Given this list of marker genes COQ8A, SYNE2, SHROOM1, GALC, KMT5B, CYP4F2, SRR, HTATSF1, DCN (decorin), CFHR1, ZNF419, MUSTN1, CLCC1, ALDH6A1, CORIN, EVA1A, SULT1B1 (sulfotransferase family 1B member 1), GLYAT, PLXNC1, DDX60, AKR1D1, CELF2, CLCN2, HAAO, UGT2A3, CRYAB, BLMH, MFN1 (NCBI Gene Id 55669), TEX21P, UGT3A2, CYP4V2, TCF21, PRLR, ENPEP, CTNNBL1, NTN1, IGF1, TTYH1, MCM10, CXCL12, SERPINE2 (NCBI Gene Id 5270), UPP2, IMMP2L, KIF1B, GAS1, TBC1D8, ABHD3, ACSS2, ACAD8, NGFR, MSI2, S100A1, TEX12, ZNF35, PRKAG2, CHCHD7, GPM6A, AASS, SLC26A3, CLEC4G, TRAF3IP2 (NCBI Gene Id 25997), EDNRA, CD320, CHPT1, PNKD, KCNQ5, PMPCB, GABRE, HIBADH, CALCRL, PARK7, OLIG1, SLC47A1, HACL1, CLEC4F, UGT2B4, CNMD, HLA-B (major histocompatibility complex, class I, B), DNASE1L3, DPYS, ACAD9, DENND2B, N4BP2L1, DCUN1D1, IL1RAP (NCBI Gene Id 3556), CYP2D6, GOT1, L2HGDH, BAG4, ACAT2, CCNF, HPGD, NAT2, SLC2A5, CYP2J2, DCT, CCR5 (NCBI Gene Id 727797), SELENOW, CLPX, TSPYL4, GFER, MAGIX, RBBP9 (RB binding protein 9, serine hydrolase), CYP8B1, MBL2, TERF2IP, SPPL2B, NDRG2, PJA1, DPYD, AGXT, STARD5, AGMAT, RGS5, FCGR2B, PDK1 (pyruvate dehydrogenase kinase 1), CD163, ITGA9, CLOCK, CES1, OTC, SLC16A2, PCCA, IDH1, CYP2G1P, SUSD4, IDO2, SIRT3, ABI3BP, SOCS7, BAAT, ACADSB, SLC22A25, ASL, PAICS, CA3, CYP2C8, PTPRO, STAB2, DCXR, TSHB, RMDN3 (regulator of microtubule dynamics 3), DSCAML1, ATAD3A, GABRA1, PTPRD, RNASEL, AADAT, FZD9, GDF10, ABCB10, NDUFB9, NR2F2, TGFB3, ABHD15, MKRN1, ALDH1A1, PCOLCE2, CD3E, PECR, EHD3 (EH domain containing 3), SLC25A15, HEMK1, SARDH, EPDR1, GPX1 (glutathione peroxidase 1), MACROD1, BHMT2, ARHGAP6, MFSD4B, ZNF865 (NCBI Gene Id 100507290), NDN, CES3, SLC17A2, KIFC2, ATG5, MDH1, CSRP3 (cysteine and glycine rich protein 3), TPRKB, HOXC9, PPP2R5C, ALDH9A1, ADAMDEC1, GLO1, ADHFE1, GDF2, GALM, LEAP2, CBS, CNGA2, CLEC3B, SLC22A7, CD1D, AHCY, HMGCS2, CKMT2, NR1H4, GSTO1, RNASEK, DENND1A, AANAT, BAD, RDH16, CD40LG, ID4, PLEKHB1, KCNK5 (NCBI Gene Id 8645), ACYP1, CPHXL, MAST3, ABAT, AMY2B, MBL1P, ACSL1, SLC10A1, SOD3, ATP11A, NAT8, DMGDH, TCF25, DDC, ETHE1, RNF19B, HAGH, SLC25A51, CYP2F1, ADH4, ALDH8A1, MTCH2, GHR, CWC15, GCDH, PDE9A, TIMM9, RAB3A, PTH1R, SUCLG2, EPHX2, GCH1, GAS2, ACAT1, GDPD3, SLC6A12, SUOX, MASP1, ADTRP, ZEB2, EFEMP1, INMT, IGFBP5, SUFU, RECK, TMEM63A, GNMT, MPDZ, CACNA1E, SLC27A5, CUTC, G6PC1, GSTK1, CTH, NR1I3, SCNN1A, FMC1, CA1, ABCC6, PBLD, TGFBI, TFPT, SERPINB1, LAMP2, BHMT, DPH7, SAFB2, STK19, SUGCT, HEBP1, HCFC1R1, QDPR, C11orf71, REPIN1, ASIC5, GABARAPL1, SPDEF, CHST15, DDX49, CYP46A1, TK1, here is a description of the gene set: from publication Sheth SS, Bodnar JS, Ghazalpour A, Thipphavong CK, Tsutsumi S, Tward AD, Demant P, Kodama T, Aburatani H, Lusis AJ (PMID 16607285) species: Mus musculus Human Gene Set: SHETH_LIVER_CANCER_VS_TXNIP_LOSS_PAM4 The molecular pathogenesis and the genetic aberrations that lead to the progression of hepatocellular carcinoma (HCC) are largely unknown. Here, we demonstrate that the thioredoxin interacting protein (Txnip) gene is a candidate tumor suppressor gene in vivo. We previously showed that the recombinant inbred congenic strain HcB-19 has a spontaneous mutation of the Txnip gene, and we now show that the strain has dramatically increased incidence of HCC, and that the HCC cosegregates with the Txnip mutation. Approximately 40% of the Txnip-deficient mice developed hepatic tumors with an increased prevalence in male mice. Visible tumors develop as early as 8 months of age. Histological analysis confirmed the morphology of HCC in the Txnip-deficient mice. Molecular markers of HCC, alpha-fetoprotein and p53, were increased in tumors of Txnip-deficient mice. The upregulation of p53 preceded tumor development; however, bromodeoxyuridine (BrdU) labeling of normal hepatic tissue of Txnip-deficient mice did not reveal increased cell proliferation. Finally, microarray analyses of tumor, non-tumor adjacent, and normal tissue of Txnip-deficient mice highlighted the genetic differences leading to the predisposition and onset of HCC. Our findings suggest that Txnip deficiency is sufficient to initiate HCC and suggest novel mechanisms in hepatocarcinogenesis. Cluster PAM4: genes down-regulated in hepatocellular carcinoma (HCC) vs normal liver tissue from mice deficient for TXNIP.